Given this list of marker genes TRAPPC2, STAT4, CLCN7, CD247, ACAN, COL2A1, TRPV4, SMAD3, COMP, SMAD2 (NCBI Gene Id 654050), ANKRD55, FRZB, HLA-B, PTPN2, PTPN22, IL2RA, GDF5, IL2RB, here is a description of the gene set: Hip osteoarthritis Human Gene Set: HP_HIP_OSTEOARTHRITIS species: Homo sapiens